The following is a description of a gene set: LDL clearance Mouse Gene Set: REACTOME_LDL_CLEARANCE studied in species Mus musculus, and this is the list of marker genes: Ces3a, Clta, Ldlrap1, Cltc, Npc1, Ces3b, Soat2, Ldlr, Ap2s1, Ap2b1, Apob, Pcsk9, Ap2m1, Nceh1, Ap2a1, Soat1, Ap2a2, Npc2, Lipa